The following is a description of a gene set: Genes up-regulated in monocytes (24h): untreated versus muramyl dipeptide andM. tuberculosis 19 kDa lipopeptide. species: Homo sapiens human blood monocytes were isolated, activated and harvested at several timepoints In this study, we identified genes that were differentially expressed in human monocytes activated with eiter NOD2L and/or TLR2/1L. from publication Schenk M, Krutzik SR, Sieling PA, Lee DJ, Teles RM, Ochoa MT, Komisopoulou E, Sarno EN, Rea TH, Graeber TG, Kim S, Cheng G, Modlin RL (PMID 22447076) Human Gene Set: GSE34156_UNTREATED_VS_24H_NOD2_AND_TLR1_TLR2_LIGAND_TREATED_MONOCYTE_UP, and this is the list of marker genes: P2RX4, PTK2B, WDR1 (WD repeat domain 1), RTN3, LINC02915, KIT, S100A11, ASZ1, GDI1, MELTF, NEURL1, TMEM230, PPP6R1, SSC4D, ILF3-DT, RPN1, WWC2-AS2, JPH3, BIVM, GALNT9, KREMEN1, LATS2, RNPEP, CDH2 (NCBI Gene Id 1000), IFI30, LILRA4, NR2F1, ABHD15, DAB2IP, ABCB11, CD86, HS6ST3, DSE, FAM43A (family with sequence similarity 43 member A), TAS2R8, SLAMF1, PPAN, LFNG, PCDH18, TEAD2, MYDGF, MISFA, FURIN, EDDM3A, CNTF, FMNL1, SCART1, EPB41L4B, RNF115, CLEC12A, ANK1, CDC42EP3, SURF4, PPP4R3C, PTAFR, ZNF574, STARD8, EMX2, MUC3A, THPO, MS4A14, CRIM1, RORC, ZRSR2P1, NOTCH4, DLG5, FREM1, SPRYD3, ARF1, KIAA1614, LORICRIN, CORO1C, TIMM8A, NPM2, LPAR1, CCDC168, HPD, RPL13P5 (NCBI Gene Id 90564), CD68, DEF8, GRK2, NFAT5, RRBP1, PILRA, RNASE11, DUXAP10, IQCE, LSAMP, ENSG00000213963, MMP9, CD58, ADAMTS20, ELF4, JOSD2, ARHGAP23, CNGB1, LILRP2, ADAMTS1, FAP, CD151, RAB5A, LILRB3, ITPR3, DCAF4L1, ELL, ARK2C, GAB1, CYP17A1, ZNF705G, ACTB, SIRPA, GRN, ROPN1L, CA4, CD163, NCF1C, LSM14B, LCP1, CYTH3, SIRPB2, SNX22, INTS1, HCG9, RENBP, WNT11, UBTD1, SOX13, RGS11, ADCY2, SLC15A4, CLPTM1L, NCR3, SH3BP1, PARVB, RAB4A, CFAP73, RASAL2, G6PD, LINC02481, EYA4, TTLL4, MUC5AC, GADL1, KLRB1, GNA15, DPYSL4, PLOD2, RBP5, KCNN3, IRF5, PRKACG, SLC4A10, SLC45A4, SEC11C, SLC15A1, NES, PRSS2, SLC7A1, ZNF462 (zinc finger protein 462), PPIB, FERMT2, SLC16A3, P4HB, SOX17, CCR6, KCTD5, TFF3, PTPN11, DCBLD2, NUMB, AQP6, SERPINA10, TLN1, PLEKHO2, PNO1, ALDH7A1, R3HDML, MTTP, NCS1, ADCY9, TFR2, FOXRED2, CCSAP, HES5, GALNT16, CTSD, PNMA3, GABRE, CD40LG, GNB1 (NCBI Gene Id 87729), RGS3, DGCR5, TMEM266, ZNF702P